Given this list of marker genes CTSC, ATP2A3, BAD, NGF, NOD1, APAF1, CTSH, NKX3-1, CASP1, MAL, EBAG9, NLRP1, BEX3, CASP8AP2, BCL2L13, RACK1, here is a description of the gene set: species: Homo sapiens Human Gene Set: GOMF_PEPTIDASE_ACTIVATOR_ACTIVITY_INVOLVED_IN_APOPTOTIC_PROCESS Binds to and increases the activity of a peptidase that is involved in the apoptotic process.